Given this list of marker genes TBP, TOR1A, CHN1, POLR1C, MAFB, CLCN1, DDC, FTL, HPCA, VPS13A, PLA2G6, CYP1B1, LTBP2, TCOF1, AARS1, POLR1D (NCBI Gene Id 51082), SALL4, PANK2, FGFR2, TACSTD2, POLR1B, ATP13A2, DRD5, CP, STARD7, CPLX1, MAPT, KCTD17, THAP1, CACNA1A, FGFR3, TBC1D24, PARK7, TWIST1, MECR, TAF1, ANO3, SYNJ1 (NCBI Gene Id 8867), MYOC (NCBI Gene Id 4653), HSPG2, ATN1, TUBB4A, TEK, here is a description of the gene set: Human Gene Set: HP_ABNORMAL_EYELID_PHYSIOLOGY Any functional abnormality of the eyelid. species: Homo sapiens Abnormal eyelid physiology